The following is a description of a gene set: from publication Fardin P, Barla A, Mosci S, Rosasco L, Verri A, Varesio L (PMID 19832978) Genes in the hypoxia signature, based on analysis of nine neuroblastoma cell lines in hypoxia and normal oxygen conditions. Human Gene Set: FARDIN_HYPOXIA_9 species: Homo sapiens Gene expression signatures are clusters of genes discriminating different statuses of the cells and their definition is critical for understanding the molecular bases of diseases. The identification of a gene signature is complicated by the high dimensional nature of the data and by the genetic heterogeneity of the responding cells. The l1-l2 regularization is an embedded feature selection technique that fulfills all the desirable properties of a variable selection algorithm and has the potential to generate a specific signature even in biologically complex settings. We studied the application of this algorithm to detect the signature characterizing the transcriptional response of neuroblastoma tumor cell lines to hypoxia, a condition of low oxygen tension that occurs in the tumor microenvironment., and this is the list of marker genes: PDK1, VEGFA, DDIT4 (DNA damage inducible transcript 4), ALDOC, AK4, FAM162A, BNIP3